The following is a description of a gene set: Human Gene Set: HP_COMMUNICATING_HYDROCEPHALUS studied in species Homo sapiens Communicating hydrocephalus A form of hydrocephalus in which there is no visible obstruction to the flow of the cerebrospinal fluid between the ventricles and subarachnoid space., and this is the list of marker genes: DLG5, UHRF1, ZBTB24, SLC2A1, HERC1, CDC42BPB, PTEN, CDCA7, P4HB, TRNT1, CRTAP, HELLS, DNAI1, RNU4-2, DNMT3B, TRIM71, GCDH, MPDZ, SKI, FBN1, B4GAT1, MAN2B1, TRPV6, SEC24D